The following is a description of a gene set: species: Homo sapiens part of: Innate Immune System RIG-I-like helicases (RLHs) the retinoic acid inducible gene-I (RIG-I, DDX58) and melanoma differentiation associated gene 5 (MDA5, IFIH1) are RNA helicases that recognize viral double-stranded RNA (dsRNA) present within the cytoplasm (Yoneyama M & Fujita T 2007, 2008). Upon viral infection dsRNA is generated by positive-strand RNA virus families such as Flaviviridae and Coronaviridae, negative-strand RNA virus families including Orthomyxoviridae and Paramyxoviridae, and DNA virus families such as Herpesviridae and Adenoviridae (Weber F et al. 2006; Son KN et al. 2015). Functionally RIG-I (DDX58) and MDA5 (IFIH1) positively regulate the IFN genes in a similar fashion, however they differ in their response to different viral species. DDX58 (RIG-I) is essential for detecting influenza virus, Sendai virus, VSV and Japanese encephalitis virus (JEV), whereas IFIH1 (MDA5) is essential in sensing encephalomyocarditis virus (EMCV), Mengo virus and Theiler's virus, all of which belong to the picornavirus family. RIG-I and MDA5 signalling results in the activation of IKK epsilon and (TKK binding kinase 1) TBK1, two serine/threonine kinases that phosphorylate interferon regulatory factor 3 and 7 (IRF3 and IRF7). Upon phosphorylation, IRF3 and IRF7 translocate to the nucleus and subsequently induce interferon alpha (IFNA) and interferon beta (IFNB) gene transcription (Yoneyama M et al. 2004; Yoneyama M & Fujita T 2007, 2008). Reactome Pathway: DDX58/IFIH1-mediated induction of interferon-alpha/beta, and this is the list of marker genes: IFNA16 (NCBI Gene Id 3449), IFNA5, OTUD5, IKBKG, TKFC, NKIRAS1, APP, IFNA17, CYLD, IFNA4, UBE2D2, UBA52, 9b, FADD, 1C, NFKB1, IFNA13, NFKBIB, IFNA6, MAVS, MAP3K1, IFNA7, RELA, AGER, TBK1, UBE2D1, ISG15, HSP90AB1, TRIM4, M, HERC5, TOMM70, IKBKB, IKBKE, PIN1, TRAF3, IRF3, S100B, TAX1BP1, PCBP2, RNF135, TRAF6, IFNB1, NFKBIA, IFNA8, CREBBP, RIPK1, TRIM25, RNF216, IFIH1, DHX58, RPS27A, NLRC5, N, HMGB1, SIKE1, HSP90AA1, UBE2K, RNF125, NFKB2, S100A12, TNFAIP3, UBE2L6, CASP10, ATG12, IFNA1, NKIRAS2, IRF7, ITCH, SAA1, UBC, RIGI, UBA7, IFNA10, ATG5, IFNA14, rep, EP300, CASP8, TRAF2, UBE2D3, IFNA21 (NCBI Gene Id 3452), CHUK, UBB, IFNA2, TANK (NCBI Gene Id 10010), NLRX1